The following is a description of a gene set: Excretion of non-amino organic acids in urine. species: Homo sapiens Organic aciduria Human Gene Set: HP_ORGANIC_ACIDURIA, and this is the list of marker genes: PGM2L1, KIF1B, AGXT, CPT2, GATM, SLC13A3, LETM1, UROC1, CA5A, RET, LMBRD1, HLCS, MCCC1, GCDH, HOGA1, PCCA, TAT, CD320, HGD, TRMU, FLAD1, TAMM41, MTRR, SFXN4, HMGCL, SLC18A2, NFU1, UROS, PCCB, MYCN, HACE1, ETFA, SLC25A20, MPC1, MMADHC, SLC52A1, TFAM, OXCT1, GRHPR, NDUFS4, SLC25A19, SLC6A19, ALDH4A1, TCN2, PEX14, LMO1, ECHS1, PHOX2B, MTR, NDUFB10, ETHE1, FDFT1, HPD, ALDH6A1, ACADVL, ETFDH, NADK2, PPOX, FH, MMUT, FOCAD, COQ4, SUGCT, PEX1, ACADS, SUCLG1, POLG, SLC26A1, SLC25A1, POLRMT, DHTKD1, SLC35C1, FBXL4, MVK, SUCLA2 (succinate-CoA ligase ADP-forming subunit beta), KYNU, MMACHC, MCEE, BTD, HSPD1, ACSF3, ACADSB, PRDX1, MMAA, BCKDHA, FTCD (NCBI Gene Id 10841), HCFC1, PAH, MMAB, ALDH5A1, IVD, GATA1, UPB1, ETFB, CPOX, ABCD4, HMBS, ABCB7, ACAD9, MRPL39, IDH2, SLC25A4, CPT1A, SLC22A5, SCO1, ACAD8, ACADM, HMGCS2, DDC, HADH, ALK (ALK receptor tyrosine kinase), LIN28B, COX16, D2HGDH, MCCC2, SLC52A2, MLYCD, OXGR1, ALAD, L2HGDH, IDH1